Given this list of marker genes ST3GAL1, CEBPA, ALOX5AP, TLE3, SLC2A5 (NCBI Gene Id 6518), PIM1, CEBPE, FLNB, LPO (lactoperoxidase), PPARG, FGR, SPI1 (Spi-1 proto-oncogene), PTPN6, IER3, PLEK, GYPC, NCF1, LBR, ARHGAP45, UPP1, NDRG1, PLCB2, IDH1, here is a description of the gene set: Genes up-regulated by tretinoin (ATRA) in U937 cells (acute promyelocytic leukemia, APL) made resistant to the drug by expression of the PLZF-RARA fusion. Acute promyelocytic leukemia (APL) is associated with chromosomal translocations involving retinoic acid receptor alpha (RAR alpha) and its fusion partners including promyelocytic leukemia (PML) and promyelocytic leukemia zinc finger (PLZF). Using oligonucleotide arrays, we examined changes in global gene expression mediated by the ectopic expression of either PML/RAR alpha (retinoid-sensitive) or PLZF/RAR alpha (retinoid-resistant) in U937 cells. Of more than genes analyzed, genes were commonly up-regulated, and genes were down-regulated by both fusion proteins suggesting their role in the APL phenotype. In our APL model, for example, TNFAIP2, TNFR2, ELF4, RAR gamma, and HoxA1 were down-regulated by both fusion proteins in the absence of retinoic acid (RA). RA strongly up-regulated these genes in PML/RAR alpha, but not in PLZF/RAR alpha expressing U937 cells. Expression studies in NB4, retinoid-resistant NB4-R2, normal human CD34+ cells, and APL patient samples strongly suggest their role in the regulation of granulocytic differentiation. Furthermore, combined treatment with tumor necrosis factor alpha (TNF alpha) and RA synergistically enhanced granulocytic differentiation in NB4 cells but not in NB4-R2 cells. Our data indicate that APL pathogenesis and retinoid-induced granulocytic differentiation of APL cells involve genes in the cell death pathway, and that cooperation between the RA and TNFalpha signaling pathways exists. Targeting both the retinoid-dependent differentiation and the cell death pathways may improve leukemic therapy, especially in retinoid-resistant acute myeloid leukemia. studied in species Homo sapiens from publication Park DJ, Vuong PT, de Vos S, Douer D, Koeffler HP (PMID 12893766) Human Gene Set: PARK_TRETINOIN_RESPONSE_AND_RARA_PLZF_FUSION